The following is a description of a gene set: The process in which a relatively unspecialized cell of neural crest origin acquires the specialized features of an odontoblast, a cell on the outer surface of the dental pulp whose biological function is the creation of dentin. Human Gene Set: GOBP_ODONTOBLAST_DIFFERENTIATION species: Homo sapiens, and this is the list of marker genes: MSX1, LEF1, SERPINE1, CTNNB1, TUBB, DSPP, SMAD2, RPTOR, IPO7, NFE2L1, CEBPB, MAP1B, FAM20C, BMP4 (NCBI Gene Id 652), IFT80, BMP2, TGFB1, DLX3